The following is a description of a gene set: A change in the morphology or behavior of a myeloid leukocyte resulting from exposure to an activating factor such as a cellular or soluble ligand. studied in species Mus musculus Mouse Gene Set: GOBP_MYELOID_LEUKOCYTE_ACTIVATION, and this is the list of marker genes: Ltbr, Anxa3, Wnt5a, Mrgprx2, Muc5b, Raet1d, Ighe, Stx4a, Kcnn4, Syt11, Prg3, Snca, Cx3cl1 (C-X3-C motif chemokine ligand 1), Slc7a2, Fer, Pld2, Lilrb4b, Cbl, Mfhas1, Vamp2, Gimap3, Hyal2, Thbs1, Csf1r, Grp, Ctsc, Clec12a, Cnr2, Tnfsf9 (tumor necrosis factor (ligand) superfamily, member 9), Ubd, Hspd1, Ifng, Aif1, Stxbp2, Nectin2, Npy, Timd2, Scnn1b, Il1rl1, Ticam1, Rhoh, Tnf, Fam76b, Traf3ip2, Nmi, Snhg20 (small nucleolar RNA host gene 20), Itgam, Pla2g10, Cd300lf, Gimap5, Mir7116, Cd48, Stard7, Fcgr4, Slc11a1, Dcstamp, Bpi, Ifngr2 (interferon gamma receptor 2), Fcgr2b, Dock2, Crtc3, Flt3l, Ndrg1, Sphk1, Lyn, Timd5, Csf2, Abcc1, Mcub, C1qa, Tlr3, Myo18a, Cst7, Jund, Trem2, Cd244a, Itgb2, Gab2 (NCBI Gene Id 14389), Lat, Kmt2e, Tlr1, Tlr2, Lbp, Rbpj, Gkn2, Grn, Cd200, Cd226, Tgfbr2, Pja2, Crhr1, Fcer1a, Ptpn11, Adam9, Tafa3, Src, Lypd10, Lat2, Naglu, Fyb1, Cd300lb, Il15, Fcer1g, Tmem106a, Tnip2, Cxcr2, Unc13d, Tff2, F2rl1, Milr1, Mrgprb1, Myd88, Tex101, Rac2, Scn11a, Ywhaz, Fgr, Rabgef1, Ccl5, Camp, Jmjd6, Stxbp1, Adam10, Wnk4, Ttbk1, Ptafr, D6Wsu163e (NCBI Gene Id 28040), Stk39, Lypd11, Sbno2, Gata2, Ulbp1, Pla2g3, Pikfyve, Gpr137b, Tlr6, Tspan32, Clu, Ptpre, Mir505, Ptgds, Trim55, Cd1d1, Itgb8, Batf2, Lrrk2, Fcgr3 (NCBI Gene Id 14131), Ager, Relb, Lrfn5, Ifngr1, Stxbp3, Cebpa, Cd84, Prkcd, Lgals9, Il18, Pdpk1, Plscr2, Adora3, Nr1d1, Lcp2 (lymphocyte cytosolic protein 2), Atm, Ptgdr, Il10, Mmp8, Camk4, Chga, Cx3cr1, Ccl3, Shpk, Lilrb4a, Gata1, Cd37, Kars1, Clec4d, Ccr2, Stap1 (NCBI Gene Id 56792), Il33, Calhm2 (NCBI Gene Id 72691), Anxa1, Foxf1, Tac4, Nr4a3 (nuclear receptor subfamily 4, group A, member 3), Rasgrp1, Pram1, Ldlr, Clnk, Nppa, Trpv1, Stx11, Jun, Hamp, Plcg2, Il4, Btk, Foxp1, Dppa1, Cd300a, Trex1, Bcr, Hmox1, Batf, Pi4k2a, Ifi35, Itgb6, Tlr4 (NCBI Gene Id 21898), Bcl10, Slamf1, Irgm1, C5ar1, Timd6, Ptpn6, Pycard, Tlr9, Plscr1, Pilrb1, Spi1, Notch2, Nampt, Dysf, Hspa12a, Hmgb1, Il13, Fcer2a, Ms4a2, Enpp3, Il4ra, Cd177, Fn1, Prkce, Batf3, Rab44, Irf4, Vamp8, Klrk1, Nr4a1, Cxcl5, Pla2g2a, Itgb2l, Nppc, Hspa4, Ctsg, Tmem229b, Jak2, Lcn10, Pla2g5, Cplx2, Syk, App, Pirb, Gpr15lg, Tyrobp, Il13ra2, Nr1h3, Tslp, Adgrf5, Pla2g4a, Myo1f, Slc18a2, Psen1, Cftr, Snx4, Sucnr1, Crlf2, Havcr2, Dnase1, Ifnb1, Il16, Fes, Sphk2, Abr, Tgfb1, Rora, Dnase1l3, Pparg, Casp1, Traf6, Epsti1, Adora2b, Edn2, Kcnj8, Il18rap, Kit, Plpp6, Cnr1, Havcr1, Snap23